The following is a description of a gene set: Human Gene Set: ZHU_CMV_24_HR_UP from publication Zhu H, Cong JP, Mamtora G, Gingeras T, Shenk T (PMID 9826724) Mechanistic insights to viral replication and pathogenesis generally have come from the analysis of viral gene products, either by studying their biochemical activities and interactions individually or by creating mutant viruses and analyzing their phenotype. Now it is possible to identify and catalog the host cell genes whose mRNA levels change in response to a pathogen. We have used DNA array technology to monitor the level of approximately 6,600 human mRNAs in uninfected as compared with human cytomegalovirus-infected cells. The level of 258 mRNAs changed by a factor of 4 or more before the onset of viral DNA replication. Several of these mRNAs encode gene products that might play key roles in virus-induced pathogenesis, identifying them as intriguing targets for further study. studied in species Homo sapiens Up-regulated at 24 h following infection of primary human foreskin fibroblasts with CMV, and this is the list of marker genes: REC8, PSMC1, SRSF7, EIF4A1, PIM1, IDH3A, PSMA6, EGR1, IRF1, PFKP, CD55, GRPEL1, TRIM21, MX1, IMPA1, NUBP1, NFKBIA, HSPE1, IFITM1, MANF, LIG4, SYNGR2, RAB2B, PDP1, RANBP1, RB1, EIF4E, PSMA2, ENO2, SRF, NUP93 (nucleoporin 93), PLA2G4A, IL7R, OAS1, PSMD6, TAP1, MLLT11, MARK2, KDM5C, ENO1, GAL, TRIM22, ATP6V1C1, BCL7B, ISG15 (NCBI Gene Id 9636), UBE2S, GBP1, PSMA3, TUBA4A, NFKB1, NPM1, SLC39A14, GORASP2, TUBB2A, PSMB2, PNP, HLA-E, PSMD2, LATS2, IL11, IFI6, NAA30, GCH1, ALAS1, HSPA1A, SNRPB2, CSE1L, POLR2K, FGFR1, GGCX, TFPI2, EIF1AX, SCARB2, NR4A1, SAR1A, NAMPT (nicotinamide phosphoribosyltransferase), SSR1, EIF5, SNRPA1, IFI27, EMP2, STIP1